The following is a description of a gene set: Mouse Gene Set: GOBP_NUCLEAR_MIGRATION_ALONG_MICROTUBULE The directed movement of the nucleus along microtubules within the cell, mediated by motor proteins. species: Mus musculus, and this is the list of marker genes: Tmem201, Sun2, Sun1, Syne2, Trim58